Given this list of marker genes Clip4 (NCBI Gene Id 78785), Clip3, Camsap1, Clasp2, Aspm, Mapre1, Nav3, Rnf4, Mapre3, Slain2 (NCBI Gene Id 75991), Spry2, Kif3c, Camsap2, Kif18b, Nckap5l, Gas2l2, Cdk5rap2 (NCBI Gene Id 72853), Knstrn, Abraxas2, Spag5, Dst, Pde4dip, Gas2l1, Mapre2, Slain1, Numa1 (NCBI Gene Id 94347), Clip2, Kif2c, Svil, Tbcb, Camsap3, Ckap5, Misp (mitotic spindle positioning), Dctn1, Clip1, Nckap5, here is a description of the gene set: studied in species Mus musculus Mouse Gene Set: GOCC_MICROTUBULE_END Any end of a microtubule. Microtubule ends differ in that the so-called microtubule plus-end is the one that preferentially grows by polymerization, with respect to the minus-end.